The following is a description of a gene set: Reactome Pathway: Nef Mediated CD8 Down-regulation part of: Nef-mediates down modulation of cell surface receptors by recruiting them to clathrin adapters Human immunodeficiency virus (HIV) Nef is a membrane-associated protein decreasing surface expression of CD4, CD28, and major histocompatibility complex class I on infected cells. Nef also strongly down-modulates surface expression of the beta-chain of the CD8alphabeta receptor by accelerated endocytosis, while CD8 alpha-chain expression is less affected. Mutational analysis of the cytoplasmic tail of the CD8 beta-chain indicates that an FMK amino acid motif is critical for the Nef-induced endocytosis. Although independent of CD4, endocytosis of the CD8 beta-chain is abrogated by the same mutations in Nef that affect CD4 down-regulation, suggesting common molecular interactions. The ability to down-regulate the human CD8 beta-chain was conserved in HIV-1, HIV-2, and simian immunodeficiency virus SIVmac239 Nef and required an intact AP-2 complex. species: Homo sapiens, and this is the list of marker genes: CD8B, AP2A1, AP2S1, AP2B1, ATP6V1H, nef, AP2A2, AP2M1